Given this list of marker genes NUP50, ROPN1L, MXD3, STXBP5, CHAF1B, PSMD1, ZPBP2, CD38, GATAD1, SKA3, ANKRD29, UBR7, JMJD6, DIAPH3, CHMP5, ELAVL1, B4GALT5, PRELID3B, SLC25A13, SYVN1 (synoviolin 1), ALS2, C15orf39, DYNC2LI1, CENPK (NCBI Gene Id 64105), CSNK2A2, GINS4, KLF10, NIF3L1, PIDD1, ERG28, KIF20B, FAF2, SUV39H1, SYTL2, TTC33, SKP1, TMPO, MLF2, BLOC1S2, CORO7, HMCES, THOC5, ANLN, MEMO1, C2CD3, IFT46, MUTYH, CAPN3, ELP4 (elongator acetyltransferase complex subunit 4), CDC45, NAA20, RNF10, WEE1, CCDC51, SERINC3, PAQR4, TSPAN5 (tetraspanin 5), COPA, MMS22L, IL20RB, FDPS, KLRK1 (NCBI Gene Id 22914), SASS6, MRPL4, SMIM3, FANCD2, DLGAP5, POLA2, RAE1, HAGHL, NAA40, MLX, ARPC1A, INPP5K, FAM72A, XKR5, RBM14, C4orf46, TTC9C, DBF4, RBBP8, MRPS5, GINS1, HSPA5, LAMB3, NDC80, MED24, DESI2, SERPINB6, BRIP1, FGL2, RPE, LY96, TPI1, KDM4A, STX12, DHRS1, AP1S3, ZMAT2, YKT6 (NCBI Gene Id 63236), FOXK2, PPM1D, CLINT1, EXOSC8, SMC1A, ARHGAP25, ATP2A3, DNAJB11, CENPO (NCBI Gene Id 79172), DEK, KDM8, PITHD1, PHKG2, PTPN9, DIPK2A, PAICS, CRIP2, SEMA4C, SAAL1, SYAP1, ANXA7, MAPK11, TIPIN, IPP, AKT1, PPM1J, INTS8, NFATC2, SLC39A4, CDC14A, ZNF518B, ANAPC4, CPM, HAT1, ANXA4, GDAP2, NUCKS1, ATP10A, CASP1, YBX1, GNA11, PYGB, DUSP5, PTPRA, MPP1, RNPC3, SERHL2, STRN, TMEM41B, CYB5R4, DEPDC1B, FLNA, RRAGC, NIPSNAP1, HRAS, YPEL1, TUBA1B, TTF2, CDC73, WDR55, THOC3, POLE, NUP205, PGAM1, HSPA2, KIF23, P2RX7, LPXN, ARL6IP1, HAUS7, HMGCR, E2F8, POLK, LPIN2, GAS2L3, SLC9B2, ESS2, PCYT2 (NCBI Gene Id 5833), THAP1, ALMS1, DDIAS, MTMR4, POU2AF1, COPRS, GLUD1, AKAP12, CHST10, GIMAP7, CAPN2, VAMP3, PPP2R3C, TM6SF1, LONP2, RDM1, SDCBP2, DUT, TCF25, CDC123, COP1, NAA38, here is a description of the gene set: studied in species Homo sapiens from publication Durant L, Watford WT, Ramos HL, Laurence A, Vahedi G, Wei L, Takahashi H, Sun HW, Kanno Y, Powrie F, O'Shea JJ (PMID 20493732) Human Gene Set: GSE21670_IL6_VS_TGFB_AND_IL6_TREATED_STAT3_KO_CD4_TCELL_UP Genes up-regulated in CD4 T cells with STAT3 knockout: IL6 versus TGF beta and IL6. STAT3, an essential transcription factor with pleiotropic functions, plays critical roles in the pathogenesis of autoimmunity. Despite recent data linking STAT3 with inflammatory bowel disease, exactly how it contributes to chronic intestinal inflammation is not known. Using a T cell transfer model of colitis we found that STAT3 expression in T cells was essential for the induction of both colitis and systemic inflammation. STAT3 was critical in modulating the balance of T helper 17 (Th17) and regulatory T (Treg) cells, as well as in promoting CD4+ T cell proliferation. We used chromatin immunoprecipitation and massive parallel sequencing (ChIP-Seq) to define the genome-wide targets of STAT3 in CD4+ T cells. We found that STAT3 bound to multiple genes involved in Th17 cell differentiation, cell activation, proliferation and survival, regulating both expression and epigenetic modifications. Thus, STAT3 orchestrates multiple critical aspects of T cell function in inflammation and homeostasis.